Given this list of marker genes RNF31, TRAF2, CHUK, TRAF3, TRAF5, DIABLO, HTRA2, IKBKB, BIRC2, CD40, TRAF6, here is a description of the gene set: A protein complex that contains at least CD40 (a cell surface receptor of the tumour necrosis factor receptor (TNFR) superfamily), and other signaling molecules. Human Gene Set: GOCC_CD40_RECEPTOR_COMPLEX studied in species Homo sapiens